The following is a description of a gene set: Human Gene Set: HP_SIMPLE_EAR species: Homo sapiens The pinna has fewer folds and grooves than usual. Simple ear, and this is the list of marker genes: CREBBP, GJA8, RNU4-2, NANS, GSC, CCDC47, CAPN15, ASNS, DDB1, YY1, MED12, DHX16, POR, AHDC1, EXOC2, WDR35, EP300, GJA5, NSRP1, SMARCD2, RERE (arginine-glutamic acid dipeptide repeats), GRIP1, BICRA, ATP6V1A, EXTL3, SH3PXD2B